Given this list of marker genes DNMT1, ADM, MAP4K1, MRPL23, H2AC18, DDB2, ARHGAP45 (NCBI Gene Id 23526), SNRPB, FRZB, HMGA1, CKS2, PTPN7, ANP32B, MRPS27, H2AC8, CSK, here is a description of the gene set: studied in species Homo sapiens Human Gene Set: ZHAN_V1_LATE_DIFFERENTIATION_GENES_DN from publication Zhan F, Tian E, Bumm K, Smith R, Barlogie B, Shaughnessy J Jr (PMID 12393520) The v1LDG down-regulated set: most variable late differentiation genes (LDG) with similar expression patterns in tonsil plasma cells (TPC) and multiple myeloma (MM) samples. To identify genes linked to normal plasma cell (PC) differentiation and to classify multiple myeloma (MM) with respect to the expression patterns of these genes, we analyzed global mRNA expression in CD19-enriched B cells (BCs) from 7 tonsils, CD138-enriched PCs from 11 tonsils, 31 normal bone marrow samples, and 74 MM bone marrow samples using microarrays interrogating genes. Hierarchical clustering analyses with genes clearly segregated the 4 cell types, and chi-square and Wilcoxin rank sum tests (P <.0005) identified 359 and 500 previously defined and novel genes that distinguish tonsil BCs from tonsil PCs (early differentiation genes), and tonsil PCs from bone marrow PCs (late differentiation genes), respectively. MM as a whole was found to have dramatically variable expression of EDGs and LDGs, and one-way analysis of variance (ANOVA) was used to identify the most variable EDGs (vEDGs) and LDGs (v1LDG and v2LDG). Hierarchical cluster analysis with these genes revealed that previously defined MM gene expression subgroups (MM1-MM4) could be linked to one of the 3 normal cell types. Clustering with 30 vEDGs revealed that 13 of 18 MM4 cases clustered with tonsil BCs (P =.000 05), whereas 14 of 15 MM3 cases clustered with tonsil PCs when using 50 v1LDG (P =.000 008), and 14 of 20 MM2 cases clustered with bone marrow PCs when using 50 v2LDG (P =.000 09). MM1 showed no significant linkage with normal cell types studied. Thus, genes whose expression is linked to distinct transitions in late-stage B-cell differentiation can be used to classify MM.